Given this list of marker genes TNFRSF1A, SPPL2B, XIAP, RNF31, UL36, UBA52, MAPKAPK2, TRAF2, SPATA2, TAX1BP1, ULK1, CYLD, MADD (NCBI Gene Id 8567), OTULIN, CHUK, USP21, UBB, RACK1, UBC, STUB1, UBE2L3, RBCK1, OTUD7B, TRADD, TNF, RIPK1, UBE2D3, CLIP3, USP4, SHARPIN, FADD, OTUD1, BIRC3, IKBKE, MIB2 (NCBI Gene Id 142678), CASP8, UBE2D1, SPPL2A, USP2, UBE2D2, IKBKB, CFLAR, OPTN (optineurin), TRAF1, OPG199, TNFAIP3, IKBKG, BIRC2, TBK1, RPS27A, here is a description of the gene set: Reactome Pathway: Regulation of TNFR1 signaling studied in species Homo sapiens part of: TNF signaling Tumor necrosis factor-alpha (TNFα) is an inflammatory cytokine, that activates either cell survival (e.g.,inflammation, proliferation) or cell death upon association with TNF receptor 1 (TNFR1). Stimuli and the cellular context dictate cell fate decisions between survival and death which rely on tightly regulated mechanisms with checkpoints on many levels. The TNFR1 signaling is controlled by the interplay between post-translational modifications such as proteolytic processing by active caspases or ubiquitination/deubiquitination by LUBAC or CYLD ubiquitin-editing complexes. TNFR1-mediated NFkappaB activation leads to the pro-survival transcriptional program that is both anti-apoptotic and highly proinflammatory. The constitutive NFkappaB or AP1 activation may lead to excessive inflammation which has been associated with a variety of aggressive tumor types (Jackson-Bernitsas DG et al. 2007; Zhang JY et al. 2007). Thus, the tight regulation of TNFα:TNFR1 signaling is required to ensure the appropriate cell response to stimuli.